The following is a description of a gene set: species: Homo sapiens Genes up-regulated in CD4-positive, alpha-beta memory T cell 56d vs 0d in adults (18-45) after exposure to BCG vaccine, time point 56D, administered PO (oral). Comment: top 100 most differentially expressed genes comparing Day 0 and Day 56 responses after in vitro re-stimulation with BCG-infected autologous dendritic cells Protective efficacy of Bacillus Calmette-Guerin (BCG) may be affected by the methods and routes of vaccine administration. We have studied the safety and immunogenicity of oral (PO) and/or intradermal (ID) administration of BCG in healthy human subjects. No major safety concerns were detected in the 68 healthy adults vaccinated with PO and/or ID BCG. Although both PO and ID BCG could induce systemic Th1 responses capable of IFN-gamma production, ID BCG more strongly induced systemic Th1 responses. In contrast, stronger mucosal responses (TB-specific secretory IgA and bronchoalveolar lavage T cells) were induced by PO BCG vaccination. To generate preliminary data comparing the early gene signatures induced by mucosal and systemic BCG vaccination, CD4<sup>+</sup> memory T cells were isolated from subsets of BCG vaccinated subjects pre- (Day 0) and post-vaccination (Days 7 and 56), rested or stimulated with BCG infected dendritic cells, and then studied by Illumina BeadArray transcriptomal analysis. Notably, distinct gene expression profiles were identified both on Day 7 and Day 56 comparing the PO and ID BCG vaccinated groups by GSEA analysis. Future correlation analyses between specific gene expression patterns and distinct mucosal and systemic immune responses induced will be highly informative for TB vaccine development. Human Gene Set: HOFT_CD4_POSITIVE_ALPHA_BETA_MEMORY_T_CELL_BCG_VACCINE_AGE_18_45YO_56D_TOP_100_DEG_AFTER_IN_VITRO_RE_STIMULATION_UP from publication Hoft DF, Xia M, Zhang GL, Blazevic A, Tennant J, Kaplan C, Matuschak G, Dube TJ, Hill H, Schlesinger LS, Andersen PL, Brusic V (PMID 28853442), and this is the list of marker genes: SNRNP25, RNY1, PI16, METTL17, TUBD1, ZDHHC11, PHF20L1, SBDS, ANKRD36C, LUC7L3, CA5B, ZNF93, RPL12P6 (NCBI Gene Id 94453), COPS2, TMEM70, LYPLA2P1, PTMA, GPKOW, IFT20, RNU1-4, UBE2Z, TNFAIP8L1, DAPP1, SNORD38A